The following is a description of a gene set: species: Homo sapiens Human Gene Set: GOMF_5_N_7_METHYLGUANOSINE_5_TRIPHOSPHO_MRNA_HYDROLASE_ACTIVITY Catalysis of the reaction: a 5'-end (N7-methyl 5'-triphosphoguanosine)-ribonucleoside in mRNA + H2O = a 5'-end phospho-ribonucleoside in mRNA + N7-methyl-GDP + H+., and this is the list of marker genes: NUDT16, NUDT3, DCP1B, NUDT16L1, NUDT1, DCP1A, DCP2, NUDT7, NUDT4, NUDT5